Given this list of marker genes SH2D6, WDR11-DT, HIRA, EFNB1, MTTP, VARS2, TP53, LINC00111, ENSG00000266100 (NCBI Gene Id 101927557), RPL35AP17, ARL8BP2, DKK1 (NCBI Gene Id 22943), TADA2A, SNRPB2, SLC25A11, CDHR2, TUBB3, MFSD13A, PPIL4, ZBTB16, MPHOSPH10, ENSG00000267882, NME6, HAUS8, NAV2, IDE (NCBI Gene Id 3416), EDAR, ITPRIP, C1orf52, ARHGEF28, CLDN1, NDUFC2-KCTD14, RCC1, STX18, C15orf48, POLR1B, TANK-AS1, CYB5A, DHRS1, EIF2B3, VPS29, VTRNA1-2, MYO9B, CENPBD1P, SPART, ALKBH3, CSKMT, UPF1, ACBD4, INKA1, MAPK8, AREG, C1orf105 (chromosome 1 open reading frame 105), BMPR1B-DT, CDCA7, NDUFAF3, NAPEPLD, DHRS3, FBXO34-AS1, PISD, ZNF839, MRNIP, FLJ38576, TPI1P2, ZNF408, COMMD2, PIP4P1, ACP2, CCDC107, TMTC3, CCT3, TAF3, CALB2, CXXC5, MED30, COX16 (cytochrome c oxidase assembly factor COX16), RNF167, HNRNPC, STK17A, LTBP1, SNRPC, WDR70, KRTCAP2, CCDC59 (NCBI Gene Id 29080), STEAP1, TANK, RPN1, LINC01556, HLCS, HSPA7 (NCBI Gene Id 730050), CDC45, CEACAM7, DUSP1, SNHG22, ILF2, CEP135, MTBP, CLUL1, TRABD, DCXR, MIR548AQ, UFD1, PRUNE1, HERC3, METTL16, ZCCHC10P1, CASZ1, RNF216, ISY1, ZNF205, NME1, MRPL44 (mitochondrial ribosomal protein L44), UQCRH, TMEM87A, RNVU1-15, CARMIL2, TTC39A, CCAR2, SNAP25-AS1, PDE8A, GINS1, INTS5, ARFGAP3, PCLAF, VPS51, NKAPD1, PXT1, PDE7B-AS1, INTS6-AS1, TJP3, PYURF, PDIK1L, PRMT5-DT, DIAPH1, CCNG2, ALDH9A1, C2CD2, POLR2C (RNA polymerase II subunit C), TBC1D19, EFNA5, PSMD1, ADAP2, KCTD14, FBXO34, EXTL3, DDX46, ZNF271P, MICA, IGFL4, REG4, STX16, DDX55, VEPH1, SNRNP200, NFE2L2, CENPU, TWIST1, NDUFC2, EHD2, CYP2R1, NRL, RBM17, BACE2, MINDY1, MIR4482, PRCD, ECHDC2, ZNF425, RPS11, MTO1, MICAL3, LINC02615, TFEB, ADGRA3, KANSL2, RPL36, ARID5A, CDKN2D, ZNF391, CEP290, AHCYL2, PSMD6, WDR83OS, CD276, GCLC, LRRC8C, INO80B-WBP1, DNLZ, PIH1D2, NR2F1-AS1, BPNT1, SMAD2, TSACC, ATG16L2, PSORS1C1, RAD50, ZNF473, CSF3, H2BC18, DYRK3, FHAD1, AAR2, STX16-NPEPL1, MALAT1, EIF4E2, ZNF596, CHP1, CNOT6, ACBD5, ABCA17P, TRIM46, GPR157, FOXP1-DT, SPHK1, RAF1, LINC02168, ISY1-RAB43, FXN, RINT1, TRIM7-AS2, IGF2BP2-AS1, PIGL, DIAPH1-AS1, CA13, CHD1, SBF2, ANG, GADD45A, CRTAC1, COG2, ZNF232-AS1, GINS3, FAM98B, C12orf57, EXOC4, SLC22A5, H1-4, DAD1, RBBP5, WRAP53, RNASE4, NOC3L (NCBI Gene Id 64318), LINC02739, WDR83, CCDC180, GZF1, PTK2, TMEM101, TPD52L2, ADRM1, TMC6, SLC9A1, ATXN2L, EHD1, DHX34, IFT22, MTERF1, SLFN13, YJU2, ACACA, FOXP1, C11orf98, AGFG1, B4GAT1-DT, TPM1, AARS2, HTR5A, POC1B, FXYD3, OLA1, GTF2A2, LOX, ZNF165, ACAA2, RRP1B, RPL23AP53, KCTD3, TMEM63A, ZCCHC4, AATBC, SLC7A7, ALOXE3, LINC01990, GSTO2, RAD9B, ALG3 (ALG3 alpha-1,3- mannosyltransferase), MLF2, SNTG1, PTK2B, MRPL40, RN7SL521P, ENSG00000272195, SEC22B, RBPJL, TATDN3, TLL2, SUGCT, SDCBP2, DPP8, TRIB1, ATP5MC1P1, PCIF1 (NCBI Gene Id 63935), SNHG3, KMT5B, CDC16, NOL9, MIS18A, TMCC2, RPL35AP16, SCAMP1, MCL1, ECE2, DPH1, TAOK3, USP30, PSPC1, SEC23A, IL5 (interleukin 5), B4GALT1, INTS1, STPG1, RPPH1, EXD1, TMEM170A, KDM3B, BECN1, TERF2 (telomeric repeat binding factor 2), LINC02026, EIF3B, POC1B-GALNT4, NOB1, MIR100HG, GPR6, GUSBP1, EWSR1, KANSL3, INO80B, RBIS, NSL1, RPS13, PDIA6, DENND5A, BRF2, SKAP2, PRMT5, NAE1, PEX3, CRYBG1 (crystallin beta-gamma domain containing 1), RNU2-37P, TEFM, PAN2, ZER1, PRKG1-AS1, RHBDD3, LINC02132, FOSB, BRWD1, DCAF6 (NCBI Gene Id 55827), LINC00963, EIF5A2, SLC1A5, SYT8, TNFRSF1A, DCXR-DT, ACAT1, PCDH1, RAB11A, PIGC, TEX48, MCPH1-AS1, CIB4, RC3H2, GUSBP11, ABCC12, TIGD6, RFC1, VPS72, INHBA, PSMF1, ZNF77, LINC02332, LRP12, ARHGEF12, UQCC6, RNA5SP60, H2AC6, MPLKIP, MCEE, DALRD3, TNPO3, BORCS8, GANC, KATNB1, DECR1, C1orf131 (chromosome 1 open reading frame 131), ATL3, PPP2CB, RNF4, SEC24A, FAM153CP, SNORA57, C8G, IDH1, ZBTB34, BMPR1B, TOMM22-DT, RNVU1-27, DCP1A, RFXANK, PIKFYVE, PHLDB1, SYTL1, HMGN3, MAPK14, TACO1, CAMK2D, CYB561, ARHGAP40, BCKDK, SCARNA17, PARP6, SPDL1, MFSD4B-DT, RPL26L1, COPS7B, CD55, BICD2, SLC44A1, MCRIP2, MED4, TOMM22, SYT7 (NCBI Gene Id 9066), ZFP36L2, TRMT10A, CITED2 (Cbp/p300 interacting transactivator with Glu/Asp rich carboxy-terminal domain 2), LIMCH1, FBXW11, PIN1, ABCA3, RPL26, RNF114, NDUFS7, GNPAT, POLR3G, RAB37, SLC37A2, ZSCAN30, YPEL3, KIAA0319L, PSMB7, ABT1, DYNC2I1, KLHDC10, IFRD1, MINCR, EGLN3, FAM111A, PDE6D, VTRNA1-1, ZNF398, DRAM1, CHD2, TRIP4, GTF2H4, CCDC12, SLC35A3, CTNNB1, SLX4IP, POLG-DT, VRK3, USP40, CCDC144BP, NOP9, LINC00620, COX18, MFSD12, PARP2, BCRP2, HECTD3, TBC1D14, PGBD2, BIRC3, WDR74, ATG16L1, B4GAT1, TNFRSF6B, HMG20B, LETMD1, FOXK2, GATB, SAR1B, MRPL13 (mitochondrial ribosomal protein L13), RFK, ZYX, KRT8, DYRK4, PALM, POLG, MIR3197, FAM83G, MIR6781, MFSD4B, AGAP3, NR1H3, ZNF213-AS1, MT1E, FAM241B, H2BC5, H2AZ1-DT, GPR39, PPOX, ENSG00000237813, CGGBP1, MRPL30, PVT1, RWDD1, BORCS8-MEF2B, NXN (nucleoredoxin), DNAH14, EDRF1-DT (EDRF1 divergent transcript), RNF130, PSME3, LINC01775, TIGD1, HCP5, LRRC41, CT62, PIP5KL1, POLK, CDC73, TAGLN3 (NCBI Gene Id 29114), STX18-AS1, DENR, EXOSC3, TOP3B, SEC11A, PTPN21, PYCR3, RNU11, RBM45, METTL25, KCTD20, CLDN16, ZMYND8, FRA10AC1 (NCBI Gene Id 57208, FRA10A associated CGG repeat 1), CARINH, UBB, MKKS, MITD1, H2BC8, DNAH11, MTERF2, TXNDC15, RHBDD2, EIF3F, POP1, RBM39, CSTPP1, TMEM199, SERGEF, LINC00205, INTS6, WDR11, DCAF11, FLVCR1, NME1-NME2, LINC02273, FBXW5, SURF6, UROD, CITED4, STK10, FAM133B, C3orf38, AQR, IKZF4, JPX, API5, CCDC186, BMS1, SPRY4, MRPS31, GATAD2B, ADHFE1, NCDN, RPRD2, PPA2, RPL26L1-AS1, ADAT2, DHX40, NAXE, THSD4, LINC02593, POR, PDE12, C1orf74, YJU2B (NCBI Gene Id 81576), TMEM222, SETD6, ARHGAP1, RUVBL1-AS1, AGPAT5, LINC01962, TNS4, TAS1R1, RSL1D1 (NCBI Gene Id 26156), METTL26, TENT2, LINC01600, HSPA8, MAN1A1, ZNF232, ZNF554, NABP1, DGAT1, PSMG2, FLVCR1-DT, ZSCAN16-AS1, here is a description of the gene set: studied in species Homo sapiens Human Gene Set: TOP2B_TARGET_GENES Genes containing one or more binding sites for (TOP2B) in their promoter regions (TSS -1000,+100 bp) as identified by GTRD version 20.06 ChIP-seq harmonization. from publication Yevshin I, Sharipov R, Kolmykov S, Kondrakhin Y, Kolpakov F (PMID 30445619)